Given this list of marker genes WNT10B, FERMT1, WNT5A, SMO (smoothened, frizzled class receptor), KRT17, TNF (NCBI Gene Id 7124), SMAD4, MSX2, HPSE, MYSM1, FST, NGFR, NUMA1, CDH3, PKP3, GAL, TGFB2, TRADD, DKK4, FOXN1, here is a description of the gene set: Human Gene Set: GOBP_REGULATION_OF_HAIR_FOLLICLE_DEVELOPMENT species: Homo sapiens Any process that modulates the frequency, rate or extent of hair follicle development.